The following is a description of a gene set: studied in species Homo sapiens Human Gene Set: WP_NAD_METABOLISM NAD+ metabolism, and this is the list of marker genes: NMNAT1, SIRT7, SIRT5, NADK, NT5E, SIRT1, NMNAT3, NRK, SIRT2, CD38, SIRT3, NAMPT, SIRT6, PARP1, NMNAT2, SIRT4